Given this list of marker genes FURIN, LRRK2, CLTB, COPG1, CIDEB, ZDHHC13, ZDHHC17, ACR, TYR, OCRL, STEAP2, SPG21, CNGA4, RAB12, GOPC, STK26, TMED7, ARCN1, APP, CLTCL1, MAP6 (NCBI Gene Id 85299), RAB13, TMED3, CLRN1, GJA1, MAP6D1, ITM2B, CNGB1, NRGN, PI4KA, AP4B1, SLC2A4, TGOLN2, AP1S1, KDELR1, COPB1, KDELR3, ADAM10, PACSIN1, VPS41, IGF2R, NCALD, CNGA2, RHO, SORT1, CCDC115, STK16, CLBA1, SPPL2C, SPPL2B, DIPK2A (divergent protein kinase domain 2A), CLTC, TMED10, COPB2, DOP1A, CFTR, RAB8A, KDELR2, COPA, ATP7A, COPE, PACS1, GPR89A, CSPG5, AP1G2, BNIP1, USE1, CHIC2 (cysteine rich hydrophobic domain 2), AP1M2, AFTPH, TMED2, AP1M1, PKD1, RAB14, GNRH1, CLTA, RAB27B, AP1G1, COPG2, COPZ1, RASSF9, SPPL2A, AP1S2, SYNRG, COPZ2, AP1S3, BACE1, RAB8B, TMED9, AP1B1, TMEM199, SCYL1, SLC18A3, SCFD1, RHOQ, AP2A1, SPPL3, here is a description of the gene set: Any vesicle associated with the Golgi complex and involved in mediating transport within the Golgi or between the Golgi and other parts of the cell. Human Gene Set: GOCC_GOLGI_ASSOCIATED_VESICLE species: Homo sapiens